The following is a description of a gene set: Human Gene Set: chr4q32 studied in species Homo sapiens, and this is the list of marker genes: RPL35AP12, GLRB (glycine receptor beta), RNU4-79P, RNU6-128P, GRIA2, NPY2R-AS1, RN7SKP188, BTF3L4P4, TDO2 (tryptophan 2,3-dioxygenase), LINC02233, RPL21P51 (ribosomal protein L21 pseudogene 51), HADHAP1, MSMO1, TMEM192, LINC01179, RNU6-668P, NACA3P, FTH1P21 (ferritin heavy chain 1 pseudogene 21), TRIM60, RNA5SP170, NPY5R, CPE, MTCO2P9, SCGB1D5P, MIR578 (microRNA 578), RNY4P17, TOMM22P4, CBR4-DT, ANP32CP, LINC02433, RAPGEF2 (Rap guanine nucleotide exchange factor 2), ENSG00000287730, NUDT19P5, TLL1, TMEM144, NDUFB2P1, RNU6-1336P, MTCYBP17, LRAT, SMIM31, MIR4454, ENSG00000306151, ENSG00000249041, RXFP1, MTCO3P9, SPMIP2, ENSG00000207171, TRIM75, FAM218BP, ENSG00000271817, ENSG00000304689, FSTL5, NPY2R, NPY1R, FNIP2, RPPH1-3P, LINC02477, NOL8P1, RNU4-87P, RNU6-284P, ANXA10, PALLD-AS1, CBR4, RNA5SP171, MTHFD2P4, GASK1B-AS1, RBM46, ENSG00000249419, MTATP6P9, RN7SKP105, CTSO, MTCO1P9, AIDAP2, TMA16 (translation machinery associated 16 homolog), MTND6P17, GK3, GASK1B, GUCY1A1, MTND3P3, MTND5P9, APELA, MAP9, ENSG00000307410, MTND2P33, FABP5P12, MAP9-AS1, PDGFC, RNU2-44P, RN7SL776P, PPID, MIR3688-2, SPOCK3, TKTL2, NAF1, RPS14P7, C4orf46, YWHAEP4, YWHAQP4, RPL6P11, RNU6-853P, TRIM60P14, ETFDH, RNU2-66P, MARCHF1, FAM218A, RPL6P12, RNU6-582P, DDX60, RPL9P16, PHB1P14, TRIM61, DDX60L, PSME2P3, KLHL2, FGG, SNORD55, LINC02272, ASIC5, MTND1P22, MTND4P8, GUCY1B1, PALLD, CHORDC1P3, MIR3688-1